The following is a description of a gene set: Mouse Gene Set: LEE_AGING_CEREBELLUM_DN Ageing of the brain leads to impairments in cognitive and motor skills, and is the major risk factor for several common neurological disorders such as Alzheimer disease (AD) and Parkinson disease (PD). Recent studies suggest that normal brain ageing is associated with subtle morphological and functional alterations in specific neuronal circuits, as opposed to large-scale neuronal loss. In fact, ageing of the central nervous system in diverse mammalian species shares many features, such as atrophy of pyramidal neurons, synaptic atrophy, decrease of striatal dopamine receptors, accumulation of fluorescent pigments, cytoskeletal abnormalities, and reactive astrocytes and microglia. To provide the first global analysis of brain ageing at the molecular level, we used oligonucleotide arrays representing genes to determine the gene-expression profile of the ageing neocortex and cerebellum in mice. Ageing resulted in a gene-expression profile indicative of an inflammatory response, oxidative stress and reduced neurotrophic support in both brain regions. At the transcriptional level, brain ageing in mice displays parallels with human neurodegenerative disorders. Caloric restriction, which retards the ageing process in mammals, selectively attenuated the age-associated induction of genes encoding inflammatory and stress responses. from publication Lee CK, Weindruch R, Prolla TA (PMID 10888876) Downregulated in the cerebellum of aged adult mice (30-month) vs young adult (5-month) species: Mus musculus, and this is the list of marker genes: Pck1, Usp46, Fscn1, Mef2a, Fabp7, Serpinh1, Ptprd, Oca2, Nfkb2, Mertk, Myh6, Dpysl2, Ptprm, Cd4, Camk2g, Actr1a, Dbp, Ccn1, Col17a1 (NCBI Gene Id 12821), Itm2a, Prl2c3, Uba7, Saysd1, Nos2, Cd320, Cars1, Ccnd1, Gm5088, Tuba8 (NCBI Gene Id 53857), Pisd, Lbx1 (ladybird homeobox 1), Ache, Cnp, Galk1, H1f6, Nab2, Myl4, Crem, Tnc, Rab4b, Ddx47, Wnt8a, Slc4a1, Adra2a, Slc6a15, Clic3, Lmod2, Doc2b, Cacng1, Acta1, Xiap, Ppnr, Smtnl2, Zic2, Tcea2, Csf2, Farsa, Hgfac, Cryga, Dhx38, Thbs1, G6pc1, Mtor, Hspa4, Reg3g, Snca, Jrk, Npy1r, Nr1d1, Smarca4, Anxa7, Wwox, Taok3, Grk3, Prdm5, Lin7b